The following is a description of a gene set: part of: Interleukin-6 family signaling Reactome Pathway: Interleukin-6 signaling species: Homo sapiens Interleukin-6 (IL-6) is a pleiotropic cytokine with roles in processes including immune regulation, hematopoiesis, inflammation, oncogenesis, metabolic control and sleep. It is the founding member of a family of IL-6-related cytokines such as IL-11, IL-27 leukemia inhibitory factor (LIF), cilliary neurotrophic factor (CNTF) and oncostatin M. <br><br>The IL-6 receptor (IL6R) consists of an alpha subunit that specifically binds IL-6 and a beta subunit, IL6RB or gp130, which is the signaling component of all the receptors for cytokines related to IL-6. IL6R alpha exists in transmembrane and soluble forms. The transmembrane form is mainly expressed by hepatocytes, neutrophils, monocytes/macrophages, and some lymphocytes. Soluble forms of IL6R (sIL6R) are also expressed by these cells. Two major mechanisms for the production of sIL6R have been proposed. Alternative splicing generates a transcript lacking the transmembrane domain by using splicing donor and acceptor sites that flank the transmembrane domain coding region. This also introduces a frameshift leading to the incorporation of 10 additional amino acids at the C terminus of sIL6R.A second mechanism for the generation of sIL6R is the proteolytic cleavage or 'shedding' of membrane-bound IL-6R. Two proteases ADAM10 and ADAM17 are thought to contribute to this. sIL6R can bind IL6 and stimulate cells that express gp130 but not IL6R alpha, a process that is termed trans-signaling. This explains why many cells, including hematopoietic progenitor cells, neuronal cells, endothelial cells, smooth muscle cells, and embryonic stem cells, do not respond to IL6 alone, but show a remarkable response to IL6/sIL6R. It is clear that the trans-signaling pathway is responsible for the pro-inflammatory activities of IL-6 whereas the membrane bound receptor governs regenerative and anti-inflammatory IL-6 activities<br><br>IL6R signal transduction is mediated by two pathways:the JAK-STAT (Janus family tyrosine kinase-signal transducer and activator of transcription) pathway and the Ras-MAPK (mitogen-activated protein kinase) pathway. Negative regulators of IL-6 signaling include SOCS (suppressor of cytokine signals) and SHP2. Within the last few years different antibodies have been developed to inhibit IL-6 activity, and the first such antibodies have been introduced into the clinic for the treatment of inflammatory diseases., and this is the list of marker genes: TYK2, SOCS3, IL6, IL6ST, JAK1, STAT1, PTPN11, STAT3, JAK2, IL6R, CBL